Given this list of marker genes Nod2, Trem2, Mfhas1, Acod1, Tlr6, Lyn, here is a description of the gene set: Any process that stops, prevents, or reduces the frequency, rate, or extent of toll-like receptor 2 signaling pathway. Mouse Gene Set: GOBP_NEGATIVE_REGULATION_OF_TOLL_LIKE_RECEPTOR_2_SIGNALING_PATHWAY species: Mus musculus